The following is a description of a gene set: studied in species Mus musculus from publication Yevshin I, Sharipov R, Kolmykov S, Kondrakhin Y, Kolpakov F (PMID 30445619) Mouse Gene Set: PSIP1_TARGET_GENES Genes containing one or more binding sites for (Psip1) in their promoter regions (TSS -1000,+100 bp) as identified by GTRD version 20.06 ChIP-seq harmonization., and this is the list of marker genes: mt-Tp, mt-Tw, Gm10222, Kcnq3, mt-Nd6, Zfp988, Dnah8, Duxf1, Ino80d, mt-Nd2, Abcg2, mt-Tt, Sfi1, Crxos (NCBI Gene Id 546024), Tcea2, Gm22417, mt-Co2, Zfp998, mt-Ty, mt-Te, Rnf14, mt-Cytb, Gm15564, Tfdp1, Gm8357, Cd244a, mt-Ti (NCBI Gene Id 17733), mt-Tm, mt-Co1, mt-Td, Gm3786, Gm37450, Ift57, Neu3, Mir6236, Gm13162, Platr30, mt-Tq, Zdhhc2, Gm27242